Given this list of marker genes GAPDH, CCND2, KLHL42, PHB2, EMG1, SLC2A3, LDHB, DDX11 (DEAD/H-box helicase 11), MAGOHB, SINHCAF (SIN3-HDAC complex associated factor), TPI1, PTPN6, TEAD4, DDX47, RECQL, DERA, CLSTN3, PTMS, LRP6, YARS2, here is a description of the gene set: from publication Korkola JE, Houldsworth J, Chadalavada RS, Olshen AB, Dobrzynski D, Reuter VE, Bosl GJ, Chaganti RS (PMID 16424014) Genes from the 12p region that were up-regulated in yolk sac tumor cells compared to normal testis. studied in species Homo sapiens Human Gene Set: KORKOLA_YOLK_SAC_TUMOR_UP Adult male germ cell tumors (GCTs) comprise distinct groups: seminomas and nonseminomas, which include pluripotent embryonal carcinomas as well as other histologic subtypes exhibiting various stages of differentiation. Almost all GCTs show 12p gain, but the target genes have not been clearly defined. To identify 12p target genes, we examined Affymetrix (Santa Clara, CA) U133A+B microarray ( approximately 83% coverage of 12p genes) expression profiles of 17 seminomas, 84 nonseminoma GCTs, and 5 normal testis samples. Seventy-three genes on 12p were significantly overexpressed, including GLUT3 and REA (overexpressed in all GCTs) and CCND2 and FLJ22028 (overexpressed in all GCTs, except choriocarcinomas). We characterized a 200-kb gene cluster at 12p13.31 that exhibited coordinated overexpression in embryonal carcinomas and seminomas, which included the known stem cell genes NANOG, STELLA, and GDF3 and two previously uncharacterized genes. A search for other coordinately regulated genomic clusters of stem cell genes did not reveal any genomic regions similar to that at 12p13.31. Comparison of embryonal carcinoma with seminomas revealed relative overexpression of several stem cell-associated genes in embryonal carcinoma, including several core stemness genes (EBAF, TDGF1, and SOX2) and several downstream targets of WNT, NODAL, and FGF signaling (FGF4, NODAL, and ZFP42). Our results indicate that 12p gain is a functionally relevant change leading to activation of proliferation and reestablishment/maintenance of stem cell function through activation of key stem cell genes. Furthermore, the differential expression of core stem cell genes may explain the differences in pluripotency between embryonal carcinomas and seminomas.